The following is a description of a gene set: Human Gene Set: GOBP_MATERNAL_PLACENTA_DEVELOPMENT Maternally driven process whose specific outcome is the progression of the placenta over time, from its formation to the mature structure. The placenta is an organ of metabolic interchange between fetus and mother, partly of embryonic origin and partly of maternal origin. studied in species Homo sapiens, and this is the list of marker genes: BMPR2, PARP2, PARP1, BSG, DEDD, AKT1, JUNB, NR2F2, VDR, STC1, PTN, DCAF13, EPOR, PRDX3, CITED2, DAZAP1, GHSR, GHRL, STC2, ASH1L (NCBI Gene Id 55870), LIF, PTGIS, NODAL (nodal growth differentiation factor), CYP27B1, CTSB, PTGS2, LDOC1, SPP1, RXRB, TPPP3, TMED2, STOX2 (NCBI Gene Id 93007), TCF23, NDP, PPARD, PRDM1